Given this list of marker genes COMP, COL11A2, TRPV4, COL2A1, POLR1A, EZH2, here is a description of the gene set: The presence of a splayed (i.e.,flared) metaphyseal segment of one or more long bones of the leg. Human Gene Set: HP_FLARED_LOWER_LIMB_METAPHYSIS species: Homo sapiens Flared lower limb metaphysis